The following is a description of a gene set: Respiratory oxidation in the mitochondria produces carbon dioxide (CO2) as a waste product. CO2 is in equilibrium with bicarbonate (HCO3-) and is the body's central pH buffering system. HCO3- is charged so cannot move across membranes unaided. The bicarbonate transport proteins move bicarbonate across the membrane. There are genes which encode these transport proteins in mammals. Applying the Human Genome Organization's sytematic nomenclature to human genes, the bicarbonate transporters belong to the SLC4A and SLC26A families. Within SLC4A, there are two distinct subfamilies, functionally corresponding to the electroneutral Cl-/HCO3- exchangers and Na+-coupled HCO3- co-transporters (Romero MF et al, 2004; Cordat E and Casey JR, 2009). species: Homo sapiens part of: SLC-mediated transport of inorganic anions Reactome Pathway: Bicarbonate transporters, and this is the list of marker genes: SLC4A1, SLC4A5, SLC4A8, SLC4A4, AHCYL2, SLC4A2, SLC4A3, SLC4A7, SLC4A9, SLC4A10